The following is a description of a gene set: species: Homo sapiens Human Gene Set: GOMF_INSULIN_RECEPTOR_SUBSTRATE_BINDING Binding to an insulin receptor substrate (IRS) protein, an adaptor protein that bind to the transphosphorylated insulin and insulin-like growth factor receptors, are themselves phosphorylated and in turn recruit SH2 domain-containing signaling molecules to form a productive signaling complex., and this is the list of marker genes: ZNF592, LONP1, PIK3R1, PRKCZ, GRB2, IGF1R, PIK3CA, INSRR, NCL, PRKCD, JAK2, PIK3CB, INSR